The following is a description of a gene set: Mouse Gene Set: GOBP_REGULATION_OF_RUFFLE_ASSEMBLY Any process that modulates the frequency, rate or extent of ruffle assembly. studied in species Mus musculus, and this is the list of marker genes: Rhog, Rcc2 (regulator of chromosome condensation 2, NCBI Gene Id 72534), Ndel1, Tacstd2, Nlgn1, Evl, Arhgap24, Rdx, Sh3yl1, Wdpcp, P2ry12 (purinergic receptor P2Y, G-protein coupled 12), Usp17le, Fam98a, Icam1, Kank1, Mtor, Pfn1, Cobl, Pfn2, Eps8, Cyfip1, Rac1, Coro1c, Eps8l1, Cav1, Eps8l3, Def8, Hras, Plekhm1, Carmil2, Stap1, Eps8l2